The following is a description of a gene set: electronically inferred by orthology from the curated human pathway species: Mus musculus This event has been computationally inferred from an event that has been demonstrated in another species.<p>The inference is based on the homology mapping from PANTHER. Briefly, reactions for which all involved PhysicalEntities (in input, output and catalyst) have a mapped orthologue/paralogue (for complexes at least 75% of components must have a mapping) are inferred to the other species. part of: Generic Transcription Pathway Reactome Pathway: FOXO-mediated transcription, and this is the list of marker genes: Ep300, Foxo4, Foxo6, Sirt1, Sfn, Smad3